The following is a description of a gene set: Human Gene Set: GOMF_PYRIMIDINE_NUCLEOTIDE_SUGAR_TRANSMEMBRANE_TRANSPORTER_ACTIVITY Enables the transfer of a pyrimidine nucleotide-sugar from one side of a membrane to the other. Pyrimidine nucleotide-sugars are pyrimidine nucleotides in glycosidic linkage with a monosaccharide or monosaccharide derivative. studied in species Homo sapiens, and this is the list of marker genes: SLC35A1, SLC35D3, SLC35D1, SLC35A3, SLC35D2, SLC35A4, TMEM241, SLC35A5 (solute carrier family 35 member A5), SLC35B4, SLC35B1, SLC35A2